Given this list of marker genes SLC44A4, WFDC2, LRPAP1, SLC6A14, PREPL, ADD1, MAEA, LIFR, ADGRG6, CTBP2, SORBS2, ATRN, IFT74, ASB9, YWHAB, SERINC3, ZNF140, here is a description of the gene set: from publication Wikman H, Ruosaari S, Nymark P, Sarhadi VK, Saharinen J, Vanhala E, Karjalainen A, Hollmén J, Knuutila S, Anttila S (PMID 17297452) Human Gene Set: WIKMAN_ASBESTOS_LUNG_CANCER_UP species: Homo sapiens Asbestos is a pulmonary carcinogen known to give rise to DNA and chromosomal damage, but the exact carcinogenic mechanisms are still largely unknown. In this study, gene expression arrays were performed on lung tumor samples from 14 heavily asbestos-exposed and 14 non-exposed patients matched for other characteristics. Using a two-step statistical analysis, genes were revealed that could differentiate the tumors of asbestos-exposed from those of non-exposed patients. To identify asbestos-associated regions with DNA copy number and expressional changes, the gene expression data were combined with comparative genomic hybridization microarray data. As a result, a combinatory profile of DNA copy number aberrations and expressional changes significantly associated with asbestos exposure was obtained. Asbestos-related areas were detected in 2p21-p16.3, 3p21.31, 5q35.2-q35.3, 16p13.3, 19p13.3-p13.1 and 22q12.3-q13.1. The most prominent of these, 19p13, was further characterized by microsatellite analysis in 62 patients for the differences in allelic imbalance (AI) between the two groups of lung tumors. 79% of the exposed and 45% of the non-exposed patients (P=0.008) were found to be carriers of AI in their lung tumors. In the exposed group, AI in 19p was prevalent regardless of the histological tumor type. In adenocarcinomas, AI in 19p appeared to occur independently of the asbestos exposure. Genes positively correlated with the asbestos exposure of lung cancer patients.